Given this list of marker genes PSME4, FZD5, FMO3, CPSF6, CENPBD1P, ZCCHC2, LEO1, TOX3, GSN, ANTXR2, GRB14, ARK2C, ATAD2B, MID1, RFX3, AFF2, PCDH19, SORBS1 (NCBI Gene Id 80057), GDA, ARPP19, PGM2L1, APPL1, ZFX, KCNT2, PDS5B, USP38, ZNRF2, OSTF1, HSDL2 (NCBI Gene Id 84263), MXD1, PISD, TUT7, SGIP1, JPH1, PRPF39, TOP2B, TPT1, RNF144A, CCNC, DNAJA2, EHHADH, ACVR1C, SOX30, PELI1, DSG3, ZNF148, RBM43, KIDINS220, SRSF2, ZZZ3, SLC7A1, NUDT12, NAV2, TAF1C, SGTB, GGCT, ASPH, RAD51B, SSH2, PLEKHA3, PABPC4, G3BP2, MYT1L, NOTCH3, ST18, JAZF1, PHACTR3, MIF4GD, ACTA1, RANBP3L, FANCM, HSP90AB1, RASSF2, ZBTB11, DMD, CSNK1G3, SERINC1, MAP3K20, NUDT21, C1orf21, HSPE1-MOB4, SEM1, ST13, ATP2B2, ARMC1, CRELD2, NAA25, HMBOX1, PDLIM5, FPGT, TMEM30A, KDSR, SLC40A1, PTPN20, PABPC5, SLC38A2, KPNA4, TNRC6B, KL, NEK1, DBT, PHF20, TSC22D2 (NCBI Gene Id 9819), SP3, ELK1, NADK2, ERRFI1, QKI, EI24, NFYB, TRIM59 (NCBI Gene Id 353185), UBE2K, LBR, CTTNBP2, STOM, COL25A1, FOXO1, PCDH7, ZNF28, TEF, RNF187, SPTBN1, OPCML, SPOCK3, DDIAS, MAT2B, EPHA5, HERPUD2, RC3H1, ERLIN2, VPS13C, ADRA1D, ACTR2, C1orf210, LSM8, NAB1, MDM1, ZNF705EP, TMEM245, ZNF704, CDH13, PAG1, NAP1L2, FHIP2A, UTS2B, GUCY1A2, MDFIC, RAG1, SMURF2, UBE2G1, SLC30A4, TERB2, PFN4, RAB11FIP2, DGKH, MACF1, VIT, AKAP12, MFSD14B, PLEKHH2, TLCD4, PTPN14, COL6A6, MACO1, HTR5A, SPX, LIN7C, PREX2, HTR2C, QSER1 (NCBI Gene Id 79832), ZNF451, CADPS, LIN54, NR2F1, JADE3, CREB5, ADAMTS19, TTC33, HIPK1, USP46, AMD1, CREB1, PGAP1, FOXJ3, CDC42SE2, CALHM4 (calcium homeostasis modulator family member 4), ASB3, NUFIP2, ZNF75A, BMP4, CALCRL, HERC4, GRK5, MON2, FAM20B, ANO5, ZBTB38, GPALPP1 (GPALPP motifs containing 1), E2F8, GHR, XPC, YIPF6 (NCBI Gene Id 286451), UTRN, LCORL, ADGRL3, TOMM20, PPP4R2, CDK1, AXIN2, TMED7 (transmembrane p24 trafficking protein 7), ZNF714, ATF2, C5orf24, RPS6KA3, ARRDC4, CDC14A, FBXO22, RBBP5 (NCBI Gene Id 5929), SOX11 (NCBI Gene Id 6664), ANKS1B, ERBB4, MINDY2, MAP3K2, ZBTB10, NEDD9, MOB4, VSIG1, FGL2, FRS3, TAFA1, ZNF860, SYNPR (synaptoporin), MEF2C (myocyte enhancer factor 2C), RBMS3, MBTPS2 (membrane bound transcription factor peptidase, site 2), POU2F1, CCL18, COBLL1, TET2, GSKIP, EYA2, LIMCH1, KCNJ1, NEDD4, ANK3, C5orf15, CARD14, HMGB1, ZDHHC23, ERO1B, ALS2, CAV2 (NCBI Gene Id 858), UBE2W (NCBI Gene Id 55284), PTPN11, FRMD5, CDK6, DGKI, TMEM65, CMPK2, ZBTB20, CNOT6L, FSD1L, PRKAA1, ZNHIT6, VSTM2A, ABRAXAS2, STAG2, NDUFAF5, ASAP1, LGALSL, ENC1, ZNF507, SPATA13, GNAI3, CUL4A, LHFPL6, NETO1, NLK, PLXNC1, CCSER2, CCDC90B (coiled-coil domain containing 90B), CLN8, JAK2 (Janus kinase 2), KIAA1217, GABRB3, CASP3, FRMD6, TCEA1, ELK4 (ETS transcription factor ELK4), PTPN21 (protein tyrosine phosphatase non-receptor type 21), ZMAT3, SNX3, CDC40, DEPTOR, MECOM, LIN7A, FBXO28, PURA, AKR1C3, CHD6 (chromodomain helicase DNA binding protein 6), CREBZF, MIB1, PRKCI, RAB9B, HDAC9 (NCBI Gene Id 9734), SVIL, GPR63, LAMA1 (laminin subunit alpha 1), MIA2, STK24, RSBN1, CACNA2D1, FUT9, IL26, WDR72, CALU, MCFD2, ITGB8, RTP4, GABRB2, PLGRKT, SF3A1, KRBOX1, ZC3H12B, WNK1, PPARGC1A, STAM, CCDC88A, TEPSIN, MLEC (NCBI Gene Id 9761), PRR27, SEPHS1, KIF26A, CILK1, HSPH1, SLC25A21, CPSF4, ACADM, ANKRD29, MBNL1, TIA1, ZMYM2, DNAH5, PIK3CA, SCAI, BICRAL, CELF2, CDC73 (cell division cycle 73), PSPC1, ZNF765, RTKN2, CCDC186, RBM22, TMEM132B, ALG10B, ZNF319, CLOCK, DSC3, TMEM170A, NRIP1, TENT2, ARID5B, BARD1, CAPZA2, MLLT10, PCDHB10, GNPDA1, SLC18A2, WWP1, MAB21L1, SNAI1, TSHZ1, RASSF8, ADAMTS5, MARK1, XPO7, SRI, REV3L, RADX, ALG1, RIPPLY3, GOLIM4, TCF4, C1orf174, TRIB2, REPS2, SEC22C, LRPPRC, BPNT2, ZNF554 (zinc finger protein 554), SALL1, SLC25A20, NIPBL, GP5, ARHGEF12, EPC2, SSRP1, PAFAH1B1, FBXO43, FAM120A, FAM76B, CNKSR3, L3MBTL3, NOL4, CDC42EP3, ZDHHC6, RFX7, ZNF761, COMMD3-BMI1, SCAMP1, CRIPT, PLS1, HOOK3, TPCN1, TRMT61B, MTX3, ELAVL1, GOLGB1 (golgin B1), PDIA6, FSTL5, RBM26, ACTR3B, F13A1, GAB3, PI4K2B, MAPK1IP1L, GOPC, PPP2R5C, PROX2, MED13L, SNTB2, CTTNBP2NL, PRTG, PARP8, OGN, KCNN3, GFPT1, RYR2, CSNK1D, HNRNPC, ATXN7, MFSD4A, EIF1AX, CIRBP, C6orf62, CCDC141, NEGR1, EPM2AIP1, ERBIN, TNRC6C, SPTLC2, RAP2C, OBI1, GRID2, FRYL, NAP1L5, SECISBP2L, MYT1, GCA, MAP3K7, NAALADL2, UBE2D3, FZD4, GNG2, ELAVL2, KCNH8, RPS20, MEIOB, KCND2 (potassium voltage-gated channel subfamily D member 2), MSR1, PLCL1, UBQLN1, ABRAXAS1, AMZ2, EMP1, ONECUT2, XRN1, MICAL3, MAP4, TSSK2, SUZ12, RDM1, MTCL3, CDK17, SNRNP40 (NCBI Gene Id 9410), TC2N (tandem C2 domains, nuclear), MBD2, CADM2, HNRNPR, GRIA4, PSMD14, UBA6, PRKCA, PATJ, KLHL15, TMEM38B, PSD3, SLC2A10, TAB3, NCOA7, MAP3K13, DLK1, FAM117B, DACH2, NPR3, CD28 (CD28 molecule), DUSP19, TBX15, BLTP3B, ADARB2, SLC16A7, MARCHF6, KIAA0408, FBXL2, TFPI, ELOVL7, MTMR7, ZNF532, DEK, ARRDC3, MAP7, DR1, USH2A, BLOC1S6, CEP55, RCC1, SAMD12, TBL1XR1, GRM5, DCUN1D1, LAMP2, HTR4, TEAD1, TIFA, PFKFB3, RXYLT1, ZBTB44, SLC1A2, AP1S3, TBC1D8B, PRP4K, DIP2C (NCBI Gene Id 22982), CSNK1A1, MEGF10, DERL1, CPEB2, SNX18, IPP, FRK, ZNF512, PLEKHG1, GXYLT1, PTBP2, ZSWIM4, IRF2BP2, TIAL1, PRPS2, ZNF76, MAPK8, KRTAP4-8, RNMT, MDM2, AKR1C2, B4GALT4, ARHGEF28, CAMK2D, OTUD1, KDM7A, PABPC4L, G0S2, PLS3, AKR1C1, OLFM3, SOX9, CPEB4, CPNE4, RAB12, MDM4, SH3TC2, CLIC4, RAB1A, SCRN3, SEC23IP, DENND1B, TENT5A, ENKD1, MTMR10, MIDEAS, CDH4, ARHGAP19, PRR7, ATE1, YTHDF2, CFAP52, CA10, SAP18, RORA, BZW1, LOX, PTPN4, PAX6, GPD2, CUL2, CERS6, BRWD3 (bromodomain and WD repeat domain containing 3), AAK1, KLF3 (KLF transcription factor 3), SLC4A10, MAN2A1, MYLIP, SOX6, SKIDA1, CLPX, TMX1, ZNF736, PABIR2, IREB2, FAT4, MARF1, SEC62, CLXN, CNOT1, PTP4A1, SESN3, PHTF2, TMEM33, DDX3X, KCNQ5, TM9SF3, DUSP16, ACVR2B, SYT16 (NCBI Gene Id 83851), TTC28 (tetratricopeptide repeat domain 28), UBQLN2, MEN1, CBX1, ZNF468, PRKAR2B, TAB2, UBE2E2, VNN1, HYCC1, SPTLC3, RPS6KA6 (ribosomal protein S6 kinase A6), here is a description of the gene set: Human Gene Set: MIR4698 Genes predicted to be targets of miRBase v22 microRNA hsa-miR-4698 in miRDB v6.0 with MirTarget v4 prediction scores > 80 (high confidence targets). species: Homo sapiens from publication Chen Y, Wang X (PMID 31504780)